Given this list of marker genes RPS27A, TGFBR2, SMAD2, PPP1CA, NEDD4L, STRAP, TGFBR1, PMEPA1, MTMR4, UCHL5, PPP1CB, STUB1, SMAD7, SMURF2 (SMAD specific E3 ubiquitin protein ligase 2), PPP1CC, PPP1R15A, XPO1, UBA52 (NCBI Gene Id 7311, ubiquitin A-52 residue ribosomal protein fusion product 1), SMAD3, UBB, USP15, BAMBI, ZFYVE9, UBC, TGFB1, SMURF1, here is a description of the gene set: TGF-beta receptor signaling is downregulated by proteasome and lysosome-mediated degradation of ubiquitinated TGFBR1, SMAD2 and SMAD3, as well as by dephosphorylation of TGFBR1, SMAD2 and SMAD3. <br><br>In the nucleus, SMAD2/3:SMAD4 complex stimulates transcription of SMAD7, an inhibitory SMAD (I-SMAD). SMAD7 binds phosphorylated TGFBR1 and competes with the binding of SMAD2 and SMAD3. Binding of SMAD7 to TGBR1 can be stabilized by STRAP, a protein that simultaneously binds SMAD7 and TGFBR1. BAMBI simultaneously binds SMAD7 and activated TGFBR1, leading to downregulation of TGF-beta receptor complex signaling.<br> <br>In addition to competing with SMAD2/3 binding to TGFBR1, SMAD7 recruits protein phosphatase PP1 to phosphorylated TGFBR1, by binding to the PP1 regulatory subunit PPP1R15A (GADD34). PP1 dephosphorylates TGFBR1, preventing the activation of SMAD2/3 and propagation of TGF-beta signal. <br> <br>SMAD7 associates with several ubiquitin ligases, SMURF1, SMURF2, and NEDD4L, and recruits them to phosphorylated TGFBR1 within TGFBR complex. SMURF1, SMURF2 and NEDD4L ubiquitinate TGFBR1 (and SMAD7), targeting TGFBR complex for proteasome and lysosome-dependent degradation. The ubiquitination of TGFBR1 can be reversed by deubiquitinating enzymes, UCHL5 (UCH37) and USP15, which may be recruited to ubiquitinated TGFBR1 by SMAD7. <br> <br>Basal levels of SMAD2 and SMAD3 are maintained by SMURF2 and STUB1 ubiquitin ligases. SMURF2 is able to bind and ubiquitinate SMAD2, leading to SMAD2 degradation, but this has been questioned by a recent study of Smurf2 knockout mice. STUB1 (CHIP) binds and ubiquitinates SMAD3, leading to SMAD3 degradation. PMEPA1 can bind and sequester unphosphorylated SMAD2 and SMAD3, preventing their activation in response to TGF-beta signaling. In addition, PMEPA1 can bind and sequester phosphorylated SMAD2 and SMAD3, preventing formation of SMAD2/3:SMAD4 heterotrimer complexes. A protein phosphatase MTMR4, residing in the membrane of early endosomes, can dephosphorylate activated SMAD2 and SMAD3, preventing formation of SMAD2/3:SMAD4 complexes. <br> studied in species Homo sapiens part of: TGF-beta receptor signaling activates SMADs Reactome Pathway: Downregulation of TGF-beta receptor signaling